The following is a description of a gene set: from publication Cui A, Huang T, Li S, Ma A, Pérez JL, Sander C, Keskin DB, Wu CJ, Fraenkel E, Hacohen N (PMID 38057668) Cytokines mediate cell-cell communication in the immune system and represent important therapeutic targets. A myriad of studies have highlighted their central role in immune function, yet we lack a global view of the cellular responses of each immune cell type to each cytokine. To address this gap, the authors created the Immune Dictionary, a compendium of single-cell transcriptomic profiles of more than 17 immune cell types in response to each of 86 cytokines (>1,400 cytokine-cell type combinations) in mouse lymph nodes in vivo. A cytokine-centric view of the dictionary revealed that most cytokines induce highly cell-type-specific responses. For example, the inflammatory cytokine interleukin-1β induces distinct gene programmes in almost every cell type. A cell-type-centric view of the dictionary identified more than 66 cytokine-driven cellular polarization states across immune cell types, including previously uncharacterized states such as an interleukin-18-induced polyfunctional natural killer cell state. Mouse Gene Set: CUI_MAST_CELL_CD40L_RESPONSE_UP species: Mus musculus Genes positively differentially expressed in cell type: Mast cell upon treatment with cytokine: CD40L in mouse lymph nodes in vivo., and this is the list of marker genes: Morc2a, Ap2a1, Tmem17, Acot2, Mon1a (NCBI Gene Id 72825), Zkscan1, Cacfd1